The following is a description of a gene set: Genes predicted to be targets of miRBase v22 microRNA hsa-miR-1914-3p in miRDB v6.0 with MirTarget v4 prediction scores > 80 (high confidence targets). from publication Chen Y, Wang X (PMID 31504780) studied in species Homo sapiens Human Gene Set: MIR1914_3P, and this is the list of marker genes: KIAA1143, SYP, RAB5B, CD1C, DISC1, TRIM11, DOCK9, GOLM2, CASP2, IL24, ST6GALNAC6, BMF, VGF, ZFYVE28, DHRSX, KAAG1, DNAI1, IGLON5, GDE1, CASP14, NOVA1, FAP, TEX51 (NCBI Gene Id 101929926), COMMD9, FOXP4, CEP20, TRIM14, KCNQ3, KDM5C